The following is a description of a gene set: Human Gene Set: GSE45365_WT_VS_IFNAR_KO_CD11B_DC_DN Genes down-regulated in ITGAM+ dendritic cells: wildtype versus IFNAR1. Murine Cytomegalovirus (MCMV) infection leads to early activation of various immune cells, including B and T lymphocytes, before the actual initiation of antigen-specific adaptive immunity. This activation is partly driven by innate cytokines, including type I interferon (IFN), which are induced early after infection. The objective of this study was to address the role of type I IFN in shaping early/innate B and T cell responses to a primary acute viral infection. In order to decipher the specific impact of IFN-I on cell subsets, we performed a genome-wide expression analysis on WT splenic B and CD8 T lymphocytes isolated from C57BL/6 mixed bone marrow chimera mice. This study complements series GSE39555, which focused on early responses of NK cells and of the two subsets of conventional dendritic cells. studied in species Homo sapiens, and this is the list of marker genes: CDCA8, LMBR1, SIL1, XRN2, MSRB2, NIT1, CD63, RAB1A, GPR82, MAPRE1, SLC6A16, HSD17B11, CDKN3, STAU2, ABRAXAS2, HAUS4, MFAP3, VPS33A, OAT, HK3, ACER3, ISCA2, SMPDL3A, WDR41, XRN1, KIF14, MRLN, MYO10, L3MBTL4, ZNF547, OCRL, KIF23, NCBP3, DNAJB14, PSG11, LPP-AS2, HSBP1 (NCBI Gene Id 3281), NKIRAS1, BLTP3B (NCBI Gene Id 23074), GSTA3, B4GALT4, SFT2D2, SPECC1L, TRIQK, ATP8B4, CENPE, NDUFAF1, TECTB, HNRNPA3P1, PCOLCE2 (procollagen C-endopeptidase enhancer 2), MFSD13A, TEDDM1, ZFYVE16, CHCHD7, GAPDH, NME8, SEPHS2, PRPF18, GNAO1-DT, SLC49A4, CLINT1, MAPK6, LINC01426, PTGR1, ENY2, BAD, EHMT1, MAP2K6, DDIAS, PAPLN, TBX19, SCOC-AS1, GALNT13, DNAAF11, NLRC4, LOXL4, PSEN1, POTEM, SULT1B1, C1orf226, HBS1L, ZNRF2P1, VIPAS39, AP3B2, DRAM1, CALM3, OSCAR, TIPARP, HP, TOR1AIP2, ELOVL2-AS1, RBM11, RHOU, AURKA, PSMD1, SNORD114-3, ARL5B, ETF1, AGTRAP, NAV3, ISL2, NEDD4, RUNX1, KIF2C, PIK3CG, MAGEC2, FRK, TEX47, NCF2, HMMR, PRKCD, DIRAS3, ANKRD30BP2, NPSR1-AS1, RASL11B, ZNF780A, CHP1, DENND2C, PCMT1, ARF5, STIMATE, PLD1, PTPN1, SQOR, PGD, ARMC8, CAPZB, IDNK, SUSD5, FIG4 (FIG4 phosphoinositide 5-phosphatase), FAM110B, LINC01242, RCHY1, CNPY1, ITGA7, RAB32, RFXANK, SLC16A4, ACTR1A, C3orf85, LIN7A (NCBI Gene Id 8825), TBC1D8B, IFT20, DLC1, BRCA1, ASPM, INSIG2, MINDY2, VRK2, SIGLEC9, LINC00320, ANKRD30BP3, VIM, PIK3C3, TYRP1, ENSG00000291065, NR6A1, PEAK1, VN1R3, ADGRE1, ATXN1, LINC00470, DACH1, STRN3, EFCAB3, ZNF619, KIF27, ZKSCAN7, C1GALT1C1, MKS1, INTS6, SPTLC1, USP35, CCNB2, PAQR6, FSD1L, TEX15, BORCS8, BNC1, TMT1B, AGGF1, SYNJ1, MSTN, PCDHB4, FGF13-AS1, CCDC93, CIBAR1, CEP55, GSKIP, LMBRD2, TMEM165